The following is a description of a gene set: B cells from human tonsil and blood were sorted using flow cytometry. The human samples were processed immediately ex-vivo using markers for known B cell subsets. Genes up-regulated in comparison of naive B cell versus pre-germinal tonsil B cells. from publication Longo NS, Lugar PL, Yavuz S, Zhang W, Krijger PH, Russ DE, Jima DD, Dave SS, Grammer AC, Lipsky PE (PMID 19023113) Human Gene Set: GSE12845_NAIVE_VS_PRE_GC_TONSIL_BCELL_UP species: Homo sapiens, and this is the list of marker genes: DDX28, CHKB, FAN1, CES2 (NCBI Gene Id 8824), ZNF14, AP3M2, SETBP1, EIF1B, DNTTIP2, CYP1A1, C15orf39, HERC1, OTUD4, MARCHF3, TP53I11, CYB561D2, WBP2, FGF1, RANBP6, WIPF2, IRF1, PTCH2, DCAF15, RAB11FIP1, RIOX1, ANGEL2, EPHB6, RPS9, SC5D, SLC6A1, TLK1, NUP88, KLRB1, DOCK5, FRMD8, AHNAK, FEM1B, KIF13B, NT5E, RPS6KA5, ZBTB39, PRODH, CTDSP1, CGRRF1, CAPN10, MPPE1, KLF9, PLXNA2, UBXN1, CYP20A1, HMGCR, PRDM4, TLE3, CGGBP1, WDR6, CHD7, MRM3, PTK2B, PITPNM3, EGF, RBM12, WT1-AS, FAM3C, FBXO7, CPN2, MAFF, CRBN, SLC2A3, TRIL (TLR4 interactor with leucine rich repeats), SYNPO, IGFBP4, SPRY1, LY9, SIGIRR, DAZAP2 (DAZ associated protein 2), CNPY3, SCN10A, ARID5B, LIN7C, ING3, ZNF629, CHSY1, MPZ, SIK1, INSIG1, INO80B, CEACAM5, CLEC2B, CDK5R1, PRR5, SAP30L-AS1, NAT1, GNB5, EIF1AX, YJU2B, PTPN1, SDHAF1 (succinate dehydrogenase complex assembly factor 1), RPLP1, RPS6KB2, EIF4EBP1, JADE2, IVNS1ABP, MEIS3P1, METTL22, RPL8, HLA-B, WBP11, ERLIN2, PDLIM2, ATF3, ZNF253 (NCBI Gene Id 56242), UBE2O (ubiquitin conjugating enzyme E2 O), TLE2, ELK1, LYST, STARD13, MAN2A2, NR3C2, USPL1, PUM1, HDHD3, RHAG, FMNL1, PPP3CA, MBP, TUG1, LCN2, STX12 (NCBI Gene Id 23673), ARRB2, JUND, PPCS, SH3BGRL3, AKAP13 (A-kinase anchoring protein 13), DUSP11, R3HDM4, FXYD1, RUNDC3A, RAB29, DCP1A, ZNF394, MAP3K5, EPS15L1, SEMA4C, CA9, LIN7B (NCBI Gene Id 64130), SRC, SARAF, DYNLT1, VAMP2, MOB3B, MUC7, DNM2, ZNF154, S1PR4, DDHD2, ZNF268, MNDA, BTG1, FCGR1A, KIR2DL5A, SAMSN1, DDR1, PDE8A, NELL2, HNF1B, BANK1, MAS1, NME4, TRMO, BRD4, TICAM1, SUSD6 (sushi domain containing 6), SLC66A2, UBE2B, RGS4, INF2, C11orf21, ZNF532, TUBA1A, KRT14 (NCBI Gene Id 387571), ARAF (A-Raf proto-oncogene, serine/threonine kinase), MST1R, ARAP1, ALDOC, PI4KB, FASTK, PPFIBP2, ZNF107, CTNNA1, CCDC7, ZNF331, DUSP10, CLK1, PIGB, ZNF571, SAP30L, KLF2, LDAF1